Given this list of marker genes Abcg2, Atp6v1a, Atp6v0a1, Atp6v1g2, Ubb, Fth1, Cybrd1, Nedd8, Slc11a2, Atp6v0e2, Ftmt, Aco1, Steap3, Atp6ap1, Hfe, Rps27a, Fbxl5, Ireb2, Atp6v1g3, Atp6v0a4, Atp6v1d (ATPase, H+ transporting, lysosomal V1 subunit D), Trf, Atp6v1c2, Atp6v1e2, Cul1, Hmox2, Atp6v0c, Tcirg1, Atp6v0d1, Atp6v1f, Tfr2, Atp6v0e, Mcoln1, here is a description of the gene set: This event has been computationally inferred from an event that has been demonstrated in another species.<p>The inference is based on the homology mapping from PANTHER. Briefly, reactions for which all involved PhysicalEntities (in input, output and catalyst) have a mapped orthologue/paralogue (for complexes at least 75% of components must have a mapping) are inferred to the other species. part of: Transport of small molecules species: Mus musculus electronically inferred by orthology from the curated human pathway Reactome Pathway: Iron uptake and transport